Given this list of marker genes Gm12689, BB031773, E130102H24Rik, Gm12791, Alg6, Slc35d1, Gm12726, Insl5, Gm12717, Gm12696, Gm12690 (NCBI Gene Id 638890), Dock7, Gm26425, Foxd3, Dynlt5, Gm12701, Gm10577, Gm12687, Jak1, Gm12787, Pramel18, Efcab7, 4930456L15Rik, Gm10305, Patj, Gm12692, C8b, Gm12846, Gm25877, Gm24869, Gm12715, Oma1, Atg4c, Plpp3, Gm25124, Gm12852, Kank4os, Raver2, 0610025J13Rik, Ak4, Gm12721, Ror1, Gm10576, Gm12799, Pramel17, Prkaa2, Gm12700, C130073F10Rik, Dab1, Gm12722, 4921539E11Rik, Gm24468, Gm12796, Gm12718, Tm2d1, Ccdc50-ps, Gm12709, L1td1, Prame62, Sgip1, Dnajc6, Gm12851 (predicted gene 12851), Cachd1, Gm12691, Ube2u, Nfia, I0C0044D17Rik, Pramel19, Kank4, Ube2uos, Dnai4, Lepr, C8a, Pgm1, Gm12795, Mir101a (microRNA 101a), Usp1, Pde4b, Leprot, Gm12688, Gm12676, Gm12723, Fyb2, E130114P18Rik, Gm12716, Mier1, Itgb3bp, Gm12790, Gm22100, 0610043K17Rik, Angptl3, Gm12684, Gm12792 (NCBI Gene Id 384033), here is a description of the gene set: species: Mus musculus Mouse Gene Set: chr4C6